The following is a description of a gene set: from publication Ramalho-Santos M, Yoon S, Matsuzaki Y, Mulligan RC, Melton DA (PMID 12228720) The transcriptional profiles of mouse embryonic, neural, and hematopoietic stem cells were compared to define a genetic program for stem cells. A total of genes are enriched in all three types of stem cells, and several of these genes are clustered in the genome. When compared to differentiated cell types, stem cells express a significantly higher number of genes (represented by expressed sequence tags) whose functions are unknown. Embryonic and neural stem cells have many similarities at the transcriptional level. These results provide a foundation for a more detailed understanding of stem cell biology. Mouse Gene Set: RAMALHO_STEMNESS_UP Genes enriched in embryonic, neural and hematopoietic stem cells. species: Mus musculus, and this is the list of marker genes: Adam9, Rcn1, Bach1, Uri1, Nopchap1, Rnf4, Sapcd1, Sh3d19, Zcchc10, Bysl, Laptm4a, Elovl6, Slc4a7, Gab1, Sec23a, Ppp2r1b, Txndc9, Rnf145, Utp20, Psmd12, Zfp639, Usp9x, Ywhah, Dph5, Sec23ip, Gfer, Cpxm1, Nup35, Kank3, Gars1, Eif3j1, Snx12, Pdcd2, Bpnt2, Pkd2, Smad2 (NCBI Gene Id 319898), Mrps10, Mpdu1, Rad23b (RAD23 homolog B, nucleotide excision repair protein), Utp4, Mrpl45, Zfp930, Ankrd17, Ndufaf4, Tbrg4, Lsm2, Stam, Zfp54, Ganab, Zc3h14, Nop58, Gnb1, Tgs1, Nifk, Cops7a, Pls3, Upp1, Xpot, Wdr55, Eprs1, Dctpp1, Tbrg1, Gcat, Fbxo8, Tceal9, Acat2, Las1l, Cdk2ap1, Aldh7a1, Srsf6, Glo1, Fkbp11, Ppic, Mterf3, Cenpc1, Ube2t, Kcnab3, Smad1, Yes1, Cdkn1a, Ppp1r2, Pcf11, Ppa1, Rpl22, Fastkd5, Cttn, Zmat3, Med23 (NCBI Gene Id 70208), Tbc1d15, Zfp644, Ercc5, Blzf1 (NCBI Gene Id 66352), Rnf138, Lig3, Coprs, Zfp281, Lsg1, Tmem183a, Pafah2, Snrpc, Suclg2 (succinate-Coenzyme A ligase, GDP-forming, beta subunit), Rsl1d1, Kras, Fkbp9, Kif2a, Tjp1, Ghr, Rabggtb, Gnl2, Ptpn2, Iars1, Ctbp2, Mrps31, Gsta4, Tars2, Pla2g6, Slc7a6, Iars2, Tead2, Eif4ebp1, Ryk, Rrn3 (RRN3 RNA polymerase I transcription factor homolog (yeast)), Zzz3, Slc38a2, Rars2, 5730480H06Rik, Mrpl34, Zfp213, Crtap, Rsrc2, Socs2, Tgif2, Arih1, Gas2, Arcn1, Laptm4b, Usp10, Smarcad1, Rock2, Fhl1, Yap1, Rasa1, Mphosph10, Gcsh, Psmd11, Rpusd4, Trip6, Rnft1, Mrpl17, Mdfi, Xpo1, Rida, Elp2, Marchf7, Grwd1, Lrrc58, Mdfic, Zfx, Mrps2, Ywhab, Phtf2, Ccnd1, Tom1l1, Eif4g2, Dicer1, Itgb1, Xrcc5, Umps, Pigx, Acadm, Jagn1, Map4k3, Fcf1, Srsf3, Txnrd1, Cops4, Lima1, Abcb1b, Dnajb6, Rcl1, Pex7, Itga6, Dtymk, Rab18, Rpp14, Wdr43, Chd1, F2r, Esf1, Rimoc1, Gclm, Mtmr10, Cwc22, Stxbp3, Prpsap1, Fbxo38, Zmym4, Prpf6